Given this list of marker genes PPIL3, CWC27, PPIC, FKBP14, PPIAL4E, FKBP7, PPIE, PPWD1, GSTZ1, FKBP4 (FKBP prolyl isomerase 4, NCBI Gene Id 2288), FKBP3, FKBP10, PPIAL4H, FKBP15, FKBP5, PPIAL4D, PPIAL4F, PPIAL4C, FKBP1B, FKBP2, PPIA, PTPA, RANBP2, AIP, AIPL1, PPIAL4A, PPIH (peptidylprolyl isomerase H), RPE65 (NCBI Gene Id 6121), FKBP1C (FKBP prolyl isomerase family member 1C), PIN4, PIN1, PPIL4, PPIL1, FKBP8, PPIAL4G, NKTR, PPID, DEGS1 (delta 4-desaturase, sphingolipid 1), PPIL6, FKBP9, FKBP11, FKBP1A, PPIF, PPIG, PPIL2, PPIB, FKBP6, here is a description of the gene set: Catalysis of a reaction that interconverts cis and trans isomers. Atoms or groups are termed cis or trans to one another when they lie respectively on the same or on opposite sides of a reference plane identifiable as common among stereoisomers. species: Homo sapiens Human Gene Set: GOMF_CIS_TRANS_ISOMERASE_ACTIVITY